The following is a description of a gene set: studied in species Mus musculus The assembly of a filopodium, a thin, stiff protrusion extended by the leading edge of a motile cell such as a crawling fibroblast or amoeba, or an axonal growth cone. Mouse Gene Set: GOBP_FILOPODIUM_ASSEMBLY, and this is the list of marker genes: Srf, Fmnl3, Ccl21a, Rac1, Rala, Ppp1r16b, Cdc42, Ccl21b, Nrp1, Dbn1, Tenm1, Ripor2, Wasl, Prkcd, Dnm3, Itga6, Fnbp1l, Capzb, Spag6, Trpm2, Zmynd8, Plppr5 (NCBI Gene Id 75769), Neurl1a, Ccl21d, Daam2, Spef1, Myo10, Ezr, Fgd3, Palm, Agrn, Ephb2, Arhgef4, S1pr2, Abitram, Ccr7, Nlgn1, Dock11, Arpc2, Mien1, Rab3ip, Fgd1, Rhoq, Dmtn, Spag6l, Actr3, Ccl21e, Srgap2, Cd2ap, Fgd2, Sh3bp1, Tenm2, Gap43, Spata13, Stau2, Tgfb3, Dpysl3, Pik3r1, Rab5a, Itgb4, Myo3b, Arap1, Vstm5, Prkcq, Rab17, Ccl21f, Nrxn1, Myo3a, Gpm6a, Ppp1r9a, Ppp1r9b, Ttyh1, Tgfbr1, Arhgap44, Fgd4 (FYVE, RhoGEF and PH domain containing 4), Fscn1, Espn, Fmr1, Arf6, Cln3